Given this list of marker genes SLC6A6, SLC6A13, SLC6A12, SLC6A1, SLC6A11, SLC6A8, here is a description of the gene set: Enables the transfer of a solute or solutes from one side of a membrane to the other according to the reaction: gamma-aminobutyric acid(out) + Na+(out) + Cl-(out) = gamma-aminobutyric acid(in) + Na+(in) + Cl(in). Human Gene Set: GOMF_GAMMA_AMINOBUTYRIC_ACID_SODIUM_CHLORIDE_SYMPORTER_ACTIVITY studied in species Homo sapiens